The following is a description of a gene set: Genes with high-CpG-density promoters (HCP) bearing histone H3 K27 trimethylation mark (H327me3) in embryonic stem cells (ES). Mouse Gene Set: MIKKELSEN_ES_HCP_WITH_H3K27ME3 from publication Mikkelsen TS, Ku M, Jaffe DB, Issac B, Lieberman E, Giannoukos G, Alvarez P, Brockman W, Kim TK, Koche RP, Lee W, Mendenhall E, O'Donovan A, Presser A, Russ C, Xie X, Meissner A, Wernig M, Jaenisch R, Nusbaum C, Lander ES, Bernstein BE (PMID 17603471) We report the application of single-molecule-based sequencing technology for high-throughput profiling of histone modifications in mammalian cells. By obtaining over four billion bases of sequence from chromatin immunoprecipitated DNA, we generated genome-wide chromatin-state maps of mouse embryonic stem cells, neural progenitor cells and embryonic fibroblasts. We find that lysine 4 and lysine 27 trimethylation effectively discriminates genes that are expressed, poised for expression, or stably repressed, and therefore reflect cell state and lineage potential. Lysine 36 trimethylation marks primary coding and non-coding transcripts, facilitating gene annotation. Trimethylation of lysine 9 and lysine 20 is detected at satellite, telomeric and active long-terminal repeats, and can spread into proximal unique sequences. Lysine 4 and lysine 9 trimethylation marks imprinting control regions. Finally, we show that chromatin state can be read in an allele-specific manner by using single nucleotide polymorphisms. This study provides a framework for the application of comprehensive chromatin profiling towards characterization of diverse mammalian cell populations. species: Mus musculus, and this is the list of marker genes: Arx (NCBI Gene Id 11878), Hoxd12 (homeobox D12), Pcdhb15, Neto1, Hoxa3, Slitrk3, Slc15a3, Tfap2b, Hba-x, Zfp804a, Otop3, Phox2b, Insrr, Pcdha10, Deup1, Lypd4, Elovl3, Pcdhb20, Nr2f1, Cacna1e, Kcns1, Tdrd1 (tudor domain containing 1), Pcdhb21, Nr2f2, Pcdhb22, Hoxd8, Pcdha2, Prdm8, Dcc, Kcnd3, Ntm, Pcdha3 (NCBI Gene Id 192163), Adcyap1, Tal1, Tbx5, Hoxd4, Pcdhb19, Mpped1, Kcnip1, Alox12b, Pcdhb17